Given this list of marker genes RAD51, FANCI, SLC19A2, PALB2, FANCE, PUS1, UBE2T, FANCG, MAD2L2, ALAS2, FANCF, FANCB, SLX4, ISCU, ERCC4, HSPA9, SLC25A38, BRIP1, FANCM, FANCD2, FANCL, BRCA2, RAD51C, ABCB7, PNPO, WFS1, BRCA1, LARS2, RFWD3, YARS2, FANCA, XRCC2, STEAP3, TRNT1, FANCC, here is a description of the gene set: Sideroblastic anemia Human Gene Set: HP_SIDEROBLASTIC_ANEMIA studied in species Homo sapiens Sideroblastic anemia results from a defect in the incorporation of iron into the heme molecule. A sideroblast is an erythroblast that has stainable deposits of iron in cytoplasm (this can be demonstrated by Prussian blue staining).